Given this list of marker genes FGFR3, EP300, RAD54B, FH, PDGFRL, CCND1, MLH3, AURKA, DCC (NCBI Gene Id 1630), APC, PLA2G2A, BAX, CTNNB1, PTPN12, SRC, AXIN2, PTPRJ, NRAS, TP53, PIK3CA, TLR2, BUB1B, AKT1, MCC, BUB1, FLCN, BRAF, DLC1, here is a description of the gene set: Human Gene Set: HP_LEIOMYOSARCOMA A smooth muscle connective tissue tumor, which is rare type of cancer that is a malignant neoplasm of smooth muscle. When such a neoplasm is benign, it is called a leiomyoma. Leiomyosarcoma species: Homo sapiens